The following is a description of a gene set: The radial migration of a pyramidal neuron along radial glial cells. species: Mus musculus Mouse Gene Set: GOBP_RADIAL_GLIA_GUIDED_PYRAMIDAL_NEURON_MIGRATION, and this is the list of marker genes: Zmiz1, Dab1, Foxg1, Disc1, Pafah1b1, Ndel1